The following is a description of a gene set: The presence of a papillary adenocarcinoma of the ovary. Human Gene Set: HP_OVARIAN_PAPILLARY_ADENOCARCINOMA Ovarian papillary adenocarcinoma studied in species Homo sapiens, and this is the list of marker genes: PRKN, OPCML, PIK3CA, AKT1, CDH1, ERBB2, CTNNB1